The following is a description of a gene set: Human Gene Set: GOMF_PLATELET_DERIVED_GROWTH_FACTOR_BINDING species: Homo sapiens Binding to platelet-derived growth factor., and this is the list of marker genes: COL5A1, PDGFRB, COL1A2, PDGFRA, COL1A1, COL2A1 (NCBI Gene Id 444981), COL3A1, COL6A1, PDGFB, PDGFA, COL4A1